Given this list of marker genes Txnl4a, Lsm4, Cwc22rt1, Sf3b4, Bud13, Snrpd2, Dhx16, Rbmx2, Snrpd1, Phf5a, Cwc22rt6, Lsm7, Sf3a1, Snrpb, Snu13, Prpf31, Srrm2, Prpf8, Cwc22rt7, Prpf38a, Mfap1b, Snrpb2 (U2 small nuclear ribonucleoprotein B), Cwc22, Rnf113a1, Lsm6, Cwc22rt5, Mfap1a, Snrpd3, Lsm5, Prpf3, Lsm3 (NCBI Gene Id 70029), Snrnp200, Prpf6, Smu1, Cwc22rt4, Snrpg, Lsm2, Sf3b5, Wbp4, Eftud2, Sf3b3, Cwc22rt2, Prpf38b, Cwc22rt3, Zmat2, Lsm8, Ik, Cwc27, Snrpe, Snip1, Rnf113a2, Prpf4, Sf3b2, Sf3a2, Sf3b1, Snrpf, Sf3a3, Snrpa1, Snrpert, Magohb, Sart1, here is a description of the gene set: Mouse Gene Set: GOCC_PRECATALYTIC_SPLICEOSOME species: Mus musculus A spliceosomal complex that is formed by the recruitment of a preassembled U5-containing tri-snRNP to the prespliceosome. Although all 5 snRNPs are present, the precatalytic spliceosome is catalytically inactive. The precatalytic spliceosome includes many proteins in addition to those found in the associated snRNPs.